The following is a description of a gene set: This pathway catalogues RHOA guanine nucleotide exchange factors (GEFs), GTPase activator proteins (GAPs), GDP dissociation inhibitors (GDIs) and RHOA effectors. RHOA is one of the three best characterized RHO GTPases, the other two being RAC1 and CDC42, and is the founding member of the RHO GTPase family. RHOA regulates the cytoskeleton and cell contractility, thus playing a role in a number of cellular functions, such as adhesion, migration, survival, division, vesicle trafficking and gene expression. RHOA-regulated processes are involved in mechanotransduction, neuronal development, immune system development, and cardiovascular regulation. RHOA mutations are frequently found in cancer. Toxins of numerous pathogens target RHOA to hijack the host cytoskeleton. species: Homo sapiens part of: RHO GTPase cycle Reactome Pathway: RHOA GTPase cycle, and this is the list of marker genes: STX5, PLD1, ARHGAP28, DLC1, STOM (NCBI Gene Id 2040), PKN1, ARHGEF5, ARHGAP31, PLEKHG6, ARHGAP44, ARHGAP40, ARHGEF19, PLEKHG3, PREX2, JUP (NCBI Gene Id 3728), GMIP, ARHGAP18, ARHGAP8, ARHGAP26, ARHGAP4, ARHGAP19, ARHGAP10, VAV3, ARHGAP11A, ARHGEF4, ARHGAP9, ARHGAP5, ARHGAP30, AAAS, ARAP2, ARAP1, ARHGAP39, ARHGEF2, TMEM87A, DOCK2, FAM13A, ACBD5, RACGAP1, TMPO, DEPDC1B, ARHGAP20, OBSCN, ABR (NCBI Gene Id 82701), SNAP23, MCF2, DEF6, DIAPH3, MCAM, RASGRF2, ARHGAP24, TRIO, ARHGAP42, ARHGAP6, PIK3R1, ARHGEF28, CAV1 (caveolin 1), FMNL3, CAVIN1, LMAN1, TAGAP, DDRGK1, FLOT1, TFRC, PREX1, RTKN, ARHGEF1, RHPN1, FLOT2, SRGAP1, STK10, ARHGAP11B, ARHGAP21, BCAP31, MYO9B (myosin IXB), ARHGEF3, ARHGEF25, ARHGAP35, ARHGDIA, VAMP3, KALRN, OPHN1, ARHGEF17, STARD8, BCR, DAAM1, VAPB, ARAP3, SOWAHC, PIK3R2, SCFD1, ACTC1, ARHGEF12, RHOA, PLEKHG5, ERBIN (erbb2 interacting protein), ROCK2, SLK, ARHGEF10L, IQGAP3, FARP1, AKAP13, STBD1, ANLN, ECT2 (NCBI Gene Id 55710), TIAM1, CIT, VAV2, NGEF, PLEKHG4, LBR, C1QBP, VANGL1, PCDH7, ARHGAP23, ARHGEF15, ARHGEF40, YKT6 (YKT6 v-SNARE homolog), PKN3, IQGAP1, MACO1, ARHGEF11, DIAPH1, RHPN2, ARHGAP29, ROCK1, TJP2, ABCD3, PKN2, HMOX2, ARHGDIB, ARHGAP22, PGRMC2, VMA22, FAF2, ARHGAP1, KTN1, ARHGEF7, ARHGEF18, STARD13, ATP6AP1, TEX2, ARHGEF10, MYO9A, NET1 (NCBI Gene Id 10276), VAV1, ARHGAP32, ARHGAP45, MCF2L, EMC3